Given this list of marker genes EXOC4, NECTIN1, GAP43, LAMP5, EXOC7, TRPV2, FLRT3, ZFYVE27, here is a description of the gene set: The portion of the plasma membrane surrounding a growth cone. studied in species Homo sapiens Human Gene Set: GOCC_GROWTH_CONE_MEMBRANE